The following is a description of a gene set: A protein complex that has protein serine/threonine phosphatase activity that is polycation-stimulated (PCS), being directly stimulated by protamine, polylysine, or histone H1; it constitutes a subclass of several enzymes activated by different histones and polylysine, and consists of catalytic, scaffolding, and regulatory subunits. The catalytic and scaffolding subunits form the core enzyme, and the holoenzyme also includes the regulatory subunit. Human Gene Set: GOCC_PROTEIN_PHOSPHATASE_TYPE_2A_COMPLEX studied in species Homo sapiens, and this is the list of marker genes: PPP2CA, IER5, PPP2CB, PPP2R5A, PPP2R5E, PPP2R2B, PPP2R5D, PPP2R5B, PPP2R3A, PPP2R5C, PPP2R2C, NKD1, PPP2R2A, PPP2R3B, PPP2R1B, PTPA, PPP2R2D, PPP2R1A